The following is a description of a gene set: species: Homo sapiens from publication Figarol S, Delahaye C, Gence R, Doussine A, Cerapio JP, Brachais M, Tardy C, Béry N, Asslan R, Colinge J, Villemin JP, Maraver A, Ferrer I, Paz-Ares L, Kessler L, Burrows F, Lajoie-Mazenc I, Dongay V, Morin C, Florent A, Pagano S, Taranchon-Clermont E, Casanova A, Pradines A, Mazieres J, Favre G, Calvayrac O (PMID 38937474) Genes commonly up-regulated (p<0.01, log2FC>0.5) in drug-tolerant cells in response to EGFR-TKI treatment in at least 6 out 7 models of EGFR-mutant non-small cell lung cancer Drug-tolerance has emerged as one of the major non-genetic adaptive processes driving resistance to targeted therapies such as tyrosine kinase inhibitors (TKI) in non-small cell lung cancer (NSCLC). To identify potential hallmarks of drug-tolerant cells (DTC), we performed RNAseq and scRNAseq experiments using different models of EGFR-mutant DTC that emerged in response to EGFR-TKI (erlotinib or osimertinib) after 7-to-21 days of treatment. We combined our transcriptomic data with publicly available resources to generate a signature of drug-tolerance consisting in the most commonly overexpressed (p<0.01, Log2FC>0.5) or downregulated (p<0.01, Log2FC<0.5) genes in at least 6 out of 7 models. Human Gene Set: FIGAROL_EGFR_TKI_DRUG_TOLERANT_CELL_UP, and this is the list of marker genes: PGRMC2, MYL9, GPR155, YPEL2, HSPB8, STOX2 (NCBI Gene Id 93007), MAGED2, FNDC3B, CXXC5, FRS2, GSTM3, PSG5, TPT1-AS1, LACTB2, SYNPO, KDM5B, GAS6, EFNA1, CDK14, RNF144B, PDE5A, PRICKLE1, CALD1, TGFB2, PARD3B, GPR161, KLHL24, EPB41L4A-AS1, P3H2, PRR16, MOSPD1, CLIC2, CALCOCO1, GRAMD1A, CDK6, COL4A3, MIR22HG, SLC16A7, EDN1, LYRM9, ZNF608, AFAP1L2, RAB11FIP1, TNFAIP1, PTPRM, MRAS, TUFT1, SOX4, FZD7, PHLDB2, LURAP1L, HBEGF, RHOBTB3, ANKRD1, CHIC2, CADM1, SLC40A1, CCN1, DAPK3, ATF3, TCEANC, WDR45, DOCK11, MAP3K7CL, FAM229B, NPR3, ZDHHC17, SCD5, TP53INP2, DNAJB2, TIMP2, SHC2, GPRC5A, PEA15, DLGAP4, CERCAM, GLIPR2, ID3, ARHGAP31, PLA2G4C, ANK2, SPOCK2, SARAF, MMP24, FAM174A, KRT80, TP53INP1, ABI3BP, NIPSNAP3A, EDIL3, ICAM1, LACTB, BIRC2, OPTN, LBH, MATN2, MAP2, NEDD9, KCNK15, RCAN2, GLCCI1, THAP2, B2M, MIR181A2HG, PMP22, MBNL2, COL4A4, CRIM1, CRYAB, ATP13A4, FILIP1L, FAM13B, PALM, GABARAPL1, KRT17, AASS, RND3, BTN2A2, THBS1, ANTXR1, TRAK2, MSRB3, TMEM59, UBA7, PTPN21, SERINC1, FSTL3, ARSG, CLIC3, VWA5A, TBC1D9, HEG1, TGM1, L1CAM, APOL1, SLC43A2, UBL3, ANOS1, GNPTG, EXT1, CTSA, ATG14 (NCBI Gene Id 22863), SEMA3E, CST6, SERPING1, LEPROT, DUSP1, CTSO (cathepsin O), PCLO, MEX3B, GSTM4, KLK5, CCN2, SUSD6 (NCBI Gene Id 9766), TRIM22, KCNH1, TMOD2, TRAM1, COL5A1, ALPP, ING4, EVA1A, RRAGB, BDNF, CTIF (NCBI Gene Id 9811), RAPGEF2, PSG8, LIMS2, ZBTB20, ARHGEF17, YPEL5, STK38, SPARC, GPNMB, TMEM217, FSTL1, WNT5A, JDP2, UBE2J1, ACKR3, RGL1, DNAJB9, MFGE8, PLCE1, GADD45B, IGFBP5, BMPR2, SLC16A6, PIK3IP1, PALLD, ID4, ACSS1, SGCB, FOLR1, LAMP2, WNT4, NATD1, PXDC1, NFIX, CREBRF, TMPRSS2, VEPH1 (ventricular zone expressed PH domain containing 1), ZFYVE1, CREB5, BACH2, PCMTD1, PSG9, TRIO, ABHD4, STK38L, MAP9, NCOA7